The following is a description of a gene set: species: Homo sapiens Human Gene Set: GOMF_PROTEIN_METHYLTRANSFERASE_ACTIVITY Catalysis of the transfer of a methyl group (CH3-) to a protein., and this is the list of marker genes: CARM1, FBXO11, SUV39H1, PRMT1, PRMT2, KMT2C, PCMT1, WDR5, PRMT6, METTL21EP, KMT2D, MGMT, PRDM7, FAM86B2, KMT2E, PRDM8, DPH5, SETDB1, PRMT5, N6AMT1, SETD3, PRMT3, FAM98A, NSD1, EEF1AKMT4, EZH1, ANTKMT, SETD1A, NTMT1, EEF1AKMT2, ARMT1, CSKMT, EZH2, EEF2KMT, SETD5, NDUFAF7, SETDB2, DNMT3A, HEMK1, NSD3, ASH1L, KMT5C, LCMT1, METTL22, SETD2, PRMT8, SMYD5, VCPKMT, METTL21A, JARID2, FBLL1, PRDM13, SETD6, EEF1AKMT3, EHMT1, METTL13, KMT5B, SMYD1, SETD1B, ATPSCKMT, NTMT2, PRDM9, FBL, KMT5A, KMT2B, ICMT, PRDM2, SETD4 (SET domain containing 4), FAM86B1, TTLL12, SETMAR (SET domain and mariner transposase fusion gene), SETD7 (NCBI Gene Id 80854), SMYD3, SUV39H2, DOT1L, TRMT112, SETBP1, EEF1AKMT1, MECOM, PCMTD1, PRDM6, NSD2, FAM98B, METTL23, PRMT9, PCMTD2, PRMT7, METTL18, CAMKMT, ETFBKMT, METTL21C, EHMT2, KMT2A, METTL9, SIRT7, PRDM16, SMYD2